The following is a description of a gene set: Mouse Gene Set: GOBP_REGULATION_OF_NEURON_MIGRATION Any process that modulates the frequency, rate or extent of neuron migration. studied in species Mus musculus, and this is the list of marker genes: Il1r1, Nexmif, Phactr1, Sox14, Mapk8, Unc5c, Dab2ip, Kif20b, Rac1, Srgap2, Flna, Nrg1, Tnn, Igsf10, Gsk3b, Adam17, Camk2a, Lrig2, Unc5d, Flrt2, Col3a1, Drd2, Adgrg1 (adhesion G protein-coupled receptor G1), Gpr173, Rnf7, Tbc1d24, Nrg3, Ptprz1, Kif26a, Cdh1, Scrt2, Sema6a, Wdr62, Nkx6-1, Ntng2, Ulk4, Drd1, Arhgap32, Plaa, Zswim6, Mdk, Rapgef2, Plxnb2, Camk2b, Vrk1, Reln, Stat3, Zfp609, Sema3a, Cul5, Cxcr4, Mapk8ip3, Gnrh1, Ntng1 (netrin G1), Pax6, Nsmf, Nipbl, Scrt1, Fbxo31, Ctnna2 (NCBI Gene Id 12548), Arhgef2, Shtn1